Given this list of marker genes CAPRIN1, FBXO42, CNNM1, ATXN1, DAZ1, MICAL3, SMARCD1, NIPAL3, GTPBP3, MTF1, CRYL1 (NCBI Gene Id 51084), KALRN, TSHZ1, DAZ2, MAP3K9, PPME1, NAP1L4, OAS2, KRTAP4-8, PDC, PPP1R2, NAP1L3, ZFC3H1, CBFA2T2, EFNA5, TACC1, SNX27, KCNRG, PIANP, NELFCD, AMMECR1 (AMMECR nuclear protein 1), CDIP1, KCNB1, PHF8, PMP22, ATM, KAT6A, NPR3, NSD2, MAFG, SAMD5, ACY3, RBM15B, GABARAP, GRIA3, CLINT1, POU3F4, CD68, VPS35, GATAD2B, VAMP2, STAM, ALG8, DAZ3, CREB3L2, TENM1, FTO, GRIN3A, TGIF2, MRPL30, ZNF704, PRKN, NPTN, STIMATE, RALGAPA2, SMAP2, SYK, CDC42EP4, ESRRG, EIF4E3, FCN3, SLC22A23, CSMD3, FJX1, DIRAS2, LAD1, SF3B4, ALOXE3, ZNF117, TM9SF1, LRRC41 (NCBI Gene Id 89995), PKNOX1, NRSN2, ENTPD4, SP1, SMG6, TMOD2, INTS9, PTPRM, STX1B, ZIC5 (NCBI Gene Id 85416), ZNF706, BPNT2, PCBP2 (poly(rC) binding protein 2), SLC40A1, SHISA9, TSHZ3, GEMIN8, COL4A4, PPP1R12B, HTR5A (NCBI Gene Id 3361), TRIB3, TMEM164 (transmembrane protein 164), TRIM58 (NCBI Gene Id 25893), VAMP7, CREBBP, PGRMC2, IGF1, WBP11, NPAP1, SENP1, DENND1B, TMEM241, PCNX1, DNAJA2, CDC42, CDK15, RAD51B, ZRANB1, THRB, TM6SF2, LARS1, ANKS1A, RTN4IP1, RC3H1, LIN54, AKAP11, C5orf24, TSBP1, NFATC2IP, ZNF609, STK4, KAT7, GABRB3, CHRM5, POLDIP3, AMOTL2, CYP27B1, CBL, KIAA1549, MAP3K19, DAZ4, BAZ2A, ADIPOR2, CCNH, GSK3B, SP6, TAF2, F13A1, GMPR, RHOT1, AIDA, SFTPA1, PURA, GCA, here is a description of the gene set: Human Gene Set: MIR5681A studied in species Homo sapiens Genes predicted to be targets of miRBase v22 microRNA hsa-miR-5681a in miRDB v6.0 with MirTarget v4 prediction scores > 80 (high confidence targets). from publication Chen Y, Wang X (PMID 31504780)